Given this list of marker genes SRR, SHMT1, SHMT2, SDS, ENSG00000274276, SERINC5 (serine incorporator 5), CBS, SERINC3, PSAT1, PHGDH, PSPH, SDSL (NCBI Gene Id 113675), AGXT, here is a description of the gene set: The chemical reactions and pathways involving L-serine, the L-enantiomer of serine, i.e. (2S)-2-amino-3-hydroxypropanoic acid. Human Gene Set: GOBP_L_SERINE_METABOLIC_PROCESS studied in species Homo sapiens